The following is a description of a gene set: from publication Yamagata T, Benoist C, Mathis D (PMID 16623764) Genes down-regulated in T cells: CD4 versus CD8A. Human Gene Set: GSE3039_CD4_TCELL_VS_ALPHAALPHA_CD8_TCELL_DN species: Homo sapiens Three innate (B1-B, NKT, CD8aaT cells) and adaptive (B2-B, CD4T, CD8abT cells) cell-types were sorted by FACS. Three biological replicates for NKT, CD4T, CD8aaT, CD8abT cells and two biological replicates for B1 and B2 cells were generated and the expression profiles were determined using Affymetrix Mu74Av2 chip. Comparisons between the sample groups allow the identification of genes differentially expressed between the innate and adaptive cell-types., and this is the list of marker genes: PPM1B, TGFBI, SIVA1, FBXO34, TRMT5, LPCAT2, SCRN3, TMX2, EIF3M, PHF24, SRRM2, NELFA, CPD, GPT, BEX2, USP26, AKR1B1, BST2, CCDC70, ARHGAP18, CENPN, DMRTB1, KLRK1, MAD2L1BP, PDE7B, TMEM243, EFHD2, CDK14, IRF2BPL, RAD51, RRM2B, NUDT1, ART5, TWIST1, CASP2, TMEM209, PDPK1, CLIP1 (NCBI Gene Id 6249), TSSK3, HYPK, MCM5, PEAK1, RAB28, PIK3CG, UBE2C, HLTF, NDE1, CCDC115, TDRD7, DCPS, CD244, ALG5 (ALG5 dolichyl-phosphate beta-glucosyltransferase), MNAT1, IL25, CRYZL1, HPF1, C11orf58, RGMB, CLEC4A, PVT1, UBE2B, AATF, ERH, CEP128, STAT4, ST8SIA3, TLR3, TRIM33, C20orf96, NIBAN1, PCNA, SPAG4 (sperm associated antigen 4), AVPR1B, PFDN4, SELENOT, TRMT112, NCOA7 (NCBI Gene Id 135112), GK, EXTL3, DCTPP1, ZMPSTE24, SLA, MRPL55, RPL35, GATM, PPP1CC, DOCK8, ADCY2, HAUS1, NCF4, DMGDH (dimethylglycine dehydrogenase), GAREM2, KIF24, ANAPC1 (NCBI Gene Id 64682), MCM7, SUPT4H1, IFIH1, WDR74, ALX3, SCP2, MCM4, USP18, IFIT1, COPE, RYR3, DPP8, RPA1, MYG1, KMT2E, IFI35, CKAP2L, INKA1, SELENOV, NSA2, ISG20 (NCBI Gene Id 3669), MAT2A, PROX2 (prospero homeobox 2), ABCC3, FCGR3A, HACD2, PITX1, OIP5, BIRC5, AEBP1, CMC2, PTPRN2, KXD1, NECAP1, NPHP3, RSAD2, CDH16, S100B, CYP2A6, CRABP1, POLR2E, LYSMD3, EIF6 (eukaryotic translation initiation factor 6), ZNF281, LAMTOR1, PGBD5, CDCA3, NDUFS7, POLA1, RRM1, CENPE, CD300LF (CD300 molecule like family member f), UFC1, NAA38, MRPS33, BLMH, RWDD4, CPS1, MRPL41, CETN2, FRMD4A, NCAPH, DNAJC8, RBM41, SBDS, CKS2 (NCBI Gene Id 1164), NAP1L2, TMPRSS6, LIMD2, ZW10 (zw10 kinetochore protein), RNF217, CACUL1, SAMD9L, CMSS1, BSND, ALKBH3, CCT3, CYB5R1, NDUFA3, CHRNA2, APEX1, ITGB5, PSMA1, TGFBR1, PHB1, DCLK2, RPL39L, PPP1R14C, AURKA, TEX14, MEAF6, SYCE2, FYB1, ARHGAP22, PIN1, PAPOLB, RPP30, MCM10, KCNJ11, POLR2J, RNF39, DUSP19 (dual specificity phosphatase 19), HSD17B12, CD8A, FOXH1, FHAD1